The following is a description of a gene set: from publication Yevshin I, Sharipov R, Kolmykov S, Kondrakhin Y, Kolpakov F (PMID 30445619) species: Homo sapiens Human Gene Set: SIX4_TARGET_GENES Genes containing one or more binding sites for (SIX4) in their promoter regions (TSS -1000,+100 bp) as identified by GTRD version 20.06 ChIP-seq harmonization., and this is the list of marker genes: CLTC, STAG2, ZNF862, SIX2, PTCD1, PTPA, DLG5, CABLES1, FBXW7, CPSF4, PLXNB1, GTPBP2, OTUD5, GSE1, SMURF2, DSCAM-AS1, PPP4R3B, TMPRSS4, HSPBAP1, RND2, ANK3, C2CD4A, METTL2A, PFN2, SEMA3B, S100A1, CASTOR3P, ADA, S100A13, USP2, ZFP36L1, SLC11A2, PKD1L2, KCNG3, LRRC37A4P, CLIP1, ZFP64, OVOL2 (NCBI Gene Id 8197), GPR146, GREB1L, PPP4R3B-DT, SLC49A4